Given this list of marker genes Aqp1, Aqp11, Aqp12, Aqp5, Aqp4, Aqp8, Aqp7, Mip, here is a description of the gene set: studied in species Mus musculus electronically inferred by orthology from the curated human pathway part of: Aquaporin-mediated transport Reactome Pathway: Passive transport by Aquaporins This event has been computationally inferred from an event that has been demonstrated in another species.<p>The inference is based on the homology mapping from PANTHER. Briefly, reactions for which all involved PhysicalEntities (in input, output and catalyst) have a mapped orthologue/paralogue (for complexes at least 75% of components must have a mapping) are inferred to the other species.